Given this list of marker genes DGKD, TIMP3, MEIS1, PTGIR, AGPAT5, MFAP3L, GADD45A, PIM2, GATA2, NPAT, BROX, H4C8, H2BC15, H2AC11, TRIM13, TCEAL9, H4C14, SGMS1, SSBP2 (NCBI Gene Id 51492), PXMP4, MGME1, MIGA2, MAPK6, THBS1, CMTM5, ESAM, NT5C3A, GAS2L1, ZNF778, RYBP, TXNDC16 (thioredoxin domain containing 16), CHAMP1 (chromosome alignment maintaining phosphoprotein 1), CLK4, CTNS, ING5, ARID5B, PTP4A3, RIMOC1, PPM1A, PTK2, KLHL24, C12orf76, MYLK3, ANXA3, H4C15, MYLK, STX17, YOD1, STRADB, ARHGAP6, H2AC17, REXO2 (RNA exonuclease 2), XPNPEP1, H2AC13, H2BC7, AQP10, OPTN, RNF103, CREBZF, CNST, BPGM, LRP12, MAD2L1BP, BCL2L1, SLC16A1, TMEM64, UBL4A, TNS1, H3C10, GUCY1B1, AGO3, P2RX1, C1orf52, SLFN14, KIFAP3, CRKL, NFATC1 (nuclear factor of activated T cells 1), TMEM40, E2F1, LDB1, H2BC12, PTGS1, TRAPPC2, LTBP1 (NCBI Gene Id 4052), MFSD2B, GADD45G, TBC1D15, ZFYVE1, TNFSF4, TUBA4A, B3GNT2, TFPI, CARMIL1, FBXO30 (F-box protein 30), PPBP, LEMD3, E2F3, HSBP1L1, PEAR1, PIM1, PTDSS2, SMTN, CAVIN2, MOB1B, PDK1, PLCXD1, TBPL1, PLAG1 (NCBI Gene Id 7996, PLAG1 zinc finger), INKA1, PRIMPOL, ZNF134, MBTD1, TRAF6, LARP4, MEG3, TENT5C, ARRDC4, RHAG, LINC02284, HERC1, FAM210B (family with sequence similarity 210 member B), AEN, GNG11, ARL15, PKIG, SENP5, CPEB2, PLEKHF2, GFI1B, OTUD5, MSI2, PHTF2, RAB3IP, PELI2, GP9, H4C16, CRYM, PITPNB, SORBS1, ATP6V0A2, CMAS, CEP44, GDF15, SPHK1, USP12, SOCS2, ANKRD9, MACO1, ZNF140, RAB30, WASF1, SOS1, RAB27B, MCTP2, ZNF567, ZMYND8, H2BC4, SSX2IP, VAPB, RBM7, BLZF1, H4C2, LANCL3, COL24A1, NEXN, PPP4R3B, DLEU2 (NCBI Gene Id 8847), DAAM1, RCHY1, SIRT3, TNIK, LGALSL, CAV2, MACIR, STIM1, KALRN, MOB3C, ZNF175, NFE2, ANKRA2 (NCBI Gene Id 57763), ZNF606, ANKRD49 (ankyrin repeat domain 49), RCL1, SERPINE1, SMIM1, ABCC4, ELOVL7, NET1, ZFYVE27, TCP11L2, SLC25A17, CREBRF, POLR1C (RNA polymerase I and III subunit C), PDLIM1, TNFAIP8L1, TUBB1, TRIM24, DEPP1, DIPK1B, LYSMD3, LAT, STAM, KLHL42, PDGFB, SIAH1, PDZD8, H4C12, BTBD19, ACRBP, TMEM140, YRDC, GATA1, KLF1, H2BC18, PF4, TWSG1, PDE5A (phosphodiesterase 5A), PLD6, COX10, GP1BA, H2AC15, CA2, ICAM2 (intercellular adhesion molecule 2), CASP3, TRIM23, CLEC1B, P2RY1, MFSD14A, TRIM58, CPEB4, KIAA1586, PCGF5, HBG1, H2BC11, ACSM3, LINC01089 (NCBI Gene Id 338799), PTBP2, GAB1, MTRR, ZNF224, MITF, STON2, SAMTOR, KCTD13, ELL2, PDZK1IP1, IKZF4, KLHL5, KEL, FAXDC2, H2BC8, IGF2BP2, NT5C2, KIAA0232, BET1, RIMKLB (ribosomal modification protein rimK like family member B), SPRY1, POLR3E, CD226, CISH, TFR2, ZMYM5, TSPOAP1-AS1, RDH11, CBLB, MARCHF3, EPB41, THUMPD1, NT5M, MFSD11, SUSD1, LAPTM4B, ZNF518B, ATG9A, XRN1, GRAP2 (GRB2 related adaptor protein 2), THRA, MAP4K5, CXCL3, TXNL4B, ENDOD1, ANK1, ZSCAN18, MPL (NCBI Gene Id 4352), ZNF274, TBXA2R, ADORA2B, H2AC14, TMEM263, KDM5B, PHF1, SRSF8, WIPI1, SUOX, C2orf88, PRKAR1B, DPH2, FBXO3, SDE2, INKA2, GCLM, KIFC3, SLC39A8, LMBRD2, CDKL1, SWT1, SLC66A2, MMD, SNCA, USP20, IGF1R, CTNNAL1, RIPOR3, ZNF197 (zinc finger protein 197), NUDT4, RAB37, EGLN3, CDK7, DMTN, DCLRE1A, UTY, BBC3, MPIG6B, ATG4D, WASL, ECE1, ZNF714, LRRC8B, TXLNG, CD58, BSDC1, B4GALT4, RNF139-DT, PHF7, KHDC4, TTC33, ZBTB11, LXN, ZNF185, RIPOR2, ALOX12, OSER1-DT (OSER1 divergent transcript), DNM3, TRAPPC2B, IKZF5, HTATIP2, PKHD1L1, H2BC21, ZNF431, YES1, RBM38, HEMGN, XK, UIMC1, PDGFA, ANKRD33B, CDC16, NECAB3, BLTP3A, ATOSA, MTURN, TSC22D1, STOM, TMEM91, DENND4C, F2R, UBE2H, PRKAR2B, ACAD8, CLCN7, TSPAN32, INPP5K, KBTBD2, GMPR (guanosine monophosphate reductase), SELP, CLCN3 (chloride voltage-gated channel 3), PBX1, CCNT2 (cyclin T2), ASH1L-AS1, LINC01003, H4C11, USP42, CDK17, TAL1, here is a description of the gene set: studied in species Homo sapiens Human Gene Set: HE_LIM_SUN_FETAL_LUNG_C2_PLATELET_CELL Platelet from publication He P, Lim K, Sun D, Pett JP, Jeng Q, Polanski K, Dong Z, Bolt L, Richardson L, Mamanova L, Dabrowska M, Wilbrey-Clark A, Madissoon E, Tuong ZK, Dann E, Suo C, Goh I, Yoshida M, Nikolić MZ, Janes SM, He X, Barker RA, Teichmann SA, Marioni JC, Meyer KB, Rawlins EL (PMID 36493756)